Given this list of marker genes F8, VWF (von Willebrand factor), here is a description of the gene set: Upon secretion from the cell, FVIII circulates in a tight complex with the multimeric glycoprotein von Willebrand Factor (vWF), which is essential for maintaining stable levels of FVIII in the circulation. Genetic mutations in the F8 gene can compromise FVIII binding to vWF thus decreasing FVIII values in the plasma causing hemophilia A (HA), an X-linked recessive bleeding disorder. part of: Defective factor VIII causes hemophilia A Reactome Pathway: Defective F8 binding to von Willebrand factor species: Homo sapiens